The following is a description of a gene set: Human Gene Set: GSE36888_UNTREATED_VS_IL2_TREATED_TCELL_6H_DN Genes down-regulated in T cells: control versus IL2 stimulation for 6h. studied in species Homo sapiens from publication Lin JX, Li P, Liu D, Jin HT, He J, Ata Ur Rasheed M, Rochman Y, Wang L, Cui K, Liu C, Kelsall BL, Ahmed R, Leonard WJ (PMID 22520852) Cytokine-activated STAT proteins dimerize and bind to high-affinity motifs, and N-terminal domain-mediated oligomerization of dimers allows tetramer formation and binding to low-affinity tandem motifs, but the functions of dimers versus tetramers are unknown. We generated Stat5a and Stat5b double knock-in (DKI) N-domain mutant mice that form dimers but not tetramers, identified cytokine-regulated genes whose expression required STAT5 tetramers, and defined consensus motifs for dimers versus tetramers. Whereas Stat5- deficient mice exhibited perinatal lethality, DKI mice were viable, indicating that STAT5 dimers were sufficient for survival. Nevertheless, STAT5 DKI mice had fewer CD4+CD25+ T cells, NK cells, and CD8+ T cells, with impaired cytokine-induced proliferation and homeostatic proliferation of CD8+ T cells. DKI CD8+ T cell proliferation following viral infection was diminished and DKI Treg cells did not efficiently control colitis. Thus, tetramerization of STAT5 is dispensable for survival but is critical for cytokine responses and normal immune function., and this is the list of marker genes: TMEM119, CHCHD4, PKD1L1-AS1 (PKD1L1 antisense RNA 1), DUSP19, KIF1C (NCBI Gene Id 9713), TREML1 (triggering receptor expressed on myeloid cells like 1), POP4 (POP4 homolog, ribonuclease P/MRP subunit), LRRK1, RAB7B, ARMC10, C15orf61, RIOK2, CNBP, RAP1GDS1, FN1, SEC63, IGFL2, B3GALT1, KRT40, DNAJB11, BRCC3 (BRCA1/BRCA2-containing complex subunit 3), IFTAP, TAF9, PTCD3, GFM1, FBXO4, IQGAP2, GTF2E1, GTF3C2, PNN, ASB13, MRPS14, ZNF614, GLUD1, RBM28, NCAPD3, ELOVL6, NEUROD1, RAPH1, POLE3, AGPS, TNS1, CFDP1, FUCA2, PPT1, PIGW, CEP41, C2CD2, LCTL (lactase like), LIG3, ZC3HAV1L, ENC1, TMEM138, MDH1, COX7B, DPCD, ZNF561-AS1, AASDHPPT, THEM5, CD163L1, VSIG4, ITGB5, ARRDC3, TMTC2, HEATR3, HNRNPR, AKAP11, PRKDC, MORF4L2, HTATSF1, LGALS9, PNPO, GRSF1, COMMD10, C1orf131, CDC23, GMFB, RIOK1, TTF2, HNRNPA3, FECH, FABP4, GML, MBNL3 (muscleblind like splicing regulator 3), KLF11, PRPS2, MCRIP2, CD84 (NCBI Gene Id 8832), MRPL15, GEMIN6 (NCBI Gene Id 79833), NUP35 (nucleoporin 35), NUDCD2, AIRIM, COX18, BPNT2, NUDT15, NETO2, EEF2K, UTP18, GAL3ST4, LARP4, PGBD2, MYO1E, ATP6V1G1, MTRES1, SETD7, CD1B, PCBD1, NUDT4, PSMA5, SLC25A13, ERLIN2, PEMT, OSBPL1A, ADCK1, CLEC12B, THBS3, XPO1, FASTKD1, PON2, FABP5, TANC2, ATP5F1A, SPTSSA, PCNA, MSANTD4, NSMF, WFDC21P, UTP3, SRSF7, CMTM7, CTSA, NARS1, PRDX1, DDX28, ZNF664, TREM2, ENTR1, ACADM, PACRGL, RMDN3, TMEM70, LGMN, PPARGC1B, EPS8, TKFC, ACVR2A, AVPI1, FKBP14, GEMIN2, A2M (alpha-2-macroglobulin), TRIM47, TIMM13, ZZZ3, PDCD6, SP2-AS1 (SP2 antisense RNA 1), NCBP2, CUTC, BPNT1, ADORA2B, PTRH2, SLC16A1, CAMK1, NDC1, RHOBTB1, CRLS1, CANX, ADK, ALG2, GCLC, CCT5, KCNJ5-AS1, OTUD4, RBBP9, MYOF, HYLS1, RAB42, UCHL3, CD1E, E2F6, HMG20B, TSSK4, SLC4A7, BLOC1S2, ARMCX5, COG2, TFAM, MEX3B, ELP1, NMB, FRMD4A, TMTC4, ALG5, RABGGTB, CHML, NANP, SCO1, NDUFV3, NOL8